The following is a description of a gene set: Transcription of E2F targets under negative control by p107 (RBL1) and p130 (RBL2) in complex with HDAC1 studied in species Homo sapiens Human Gene Set: REACTOME_TRANSCRIPTION_OF_E2F_TARGETS_UNDER_NEGATIVE_CONTROL_BY_P107_RBL1_AND_P130_RBL2_IN_COMPLEX_WITH_HDAC1, and this is the list of marker genes: RBL2, RBL1, LIN52, HDAC1, TFDP2, LIN54, CCNA2, RBBP4, CDK1, E2F1, E2F5, E2F4, TFDP1, LIN37, MYBL2, LIN9